Given this list of marker genes KCNJ1, SLC12A3, CLCNKB, KCNJ10, HLA-B, HSD11B2, CLCNKA, CYP17A1, SLC12A1, BSND, SCNN1B, IKZF1, here is a description of the gene set: Hypokalemic alkalosis Human Gene Set: HP_HYPOKALEMIC_ALKALOSIS species: Homo sapiens